The following is a description of a gene set: studied in species Homo sapiens Human Gene Set: WP_BURN_WOUND_HEALING Burn wound healing, and this is the list of marker genes: HGF, NOX4, EGF (NCBI Gene Id 1950), ADAM12, ACHE, CXCL14, MMP2, TGFB2 (NCBI Gene Id 7042), MIAT, IFNA2, SERPINH1, SCEL, FBN1 (NCBI Gene Id 7470), CHRNA7, GAS5, TLR2, TNF, HEXD, MMP1, SNHG20, TP53, ELN, TAGLN, TLR4, MIR29B1, S100A9, PDGFRB, FN1, NFKB1, CCL2, S100A6, CXCL1, FGFR1, CXCR2, IL15, FGFR3 (fibroblast growth factor receptor 3), MIR29A, FGFR4, TNFAIP3, IFNB1, ACTA1, SLURP1, CASP3, BRD4, ICAM1, TLR7, IL1A, KRT222, KLF4, FGFR2, SPARC, TLR1, TGFB3, SFRP2, TNC, MMP3, LGALS1, NOD1, HMGB1, IL1B, NFKBIA, FST, CD248, AKT1, TLR6, VEGFA, FLG, S100A11, TLR5, TLR9, MYD88, CNN2, INHBA, IL6, MMP9, BCL2, CXCL8, KDR, SMAD3, COL1A1, DCN, TPT1, MMP13, CXCL12, MIR4485, KRT6A, TIMP1, BAX, AMBP, CXCR4, XIST, VIM, PECAM1 (platelet and endothelial cell adhesion molecule 1), TIMP2, HOTAIR, PFN1, FOXE1, TLR3, COL1A2, MIR126, MMP28, CD3E, LY96, MIR663B, TLR8, CDK16, F13A1, SNAI2, NOD2, MIR145, HULC, NFKBIZ, LIN28A